Given this list of marker genes MRPL9, B3GNT2, TMEM165, BBS12, AIMP2, CDK5RAP1, PWWP2B, BAIAP2-DT, RBM41, RELL1 (RELT like 1), RRP1B, TERF2, RNF44, EXOSC2, C16orf54, PSTK, PROSER1, ABCD3, PUS1, PSIP1, DDX51, OCEL1, MRPS27, GXYLT1, USP31 (NCBI Gene Id 57478), FAM118B, NAA40, MCAM, RBM4B, ANKMY2 (ankyrin repeat and MYND domain containing 2), ZFP82, CALM2, ZSCAN18, CMAS, LTV1, CAPRIN2, MAP3K5, JMY, RAP1A, TMCO3, ZNF500, ELP2, ZNF77, BTD, TGFBR2, ATOSA (NCBI Gene Id 56204), MTREX, TAF1, ZNF112, TRERF1, LONP2, IER5L, ZBTB44, COMMD8, AGO4, WDSUB1, DOK3, ELP1, HECTD1, MRPL34, RRS1, NDUFA5, MYCL, LRIG2, GSKIP, AGL, MOAP1, DGCR2, ZNF623, IL1R1, FBXW2, SET, UTP11 (UTP11 small subunit processome component), BRD3, PRDM2, RACGAP1, MDM1, MAP3K2, COMMD2, ZNF573, NUP42, AGTPBP1, TDRKH, DUT, INPP4A, NUDT6, FBXO21, TSPYL5, MRFAP1L2 (NCBI Gene Id 93623), VPS33B, TMX3, UBR5, GPATCH11 (G-patch domain containing 11), SLC25A38, SPICE1, WDR54, OXA1L, YWHAG, RNF2, DUSP7, HEATR5B (NCBI Gene Id 54497), DDX55, SLC25A48, TSN, SAP30, MIDEAS, TMEM230 (NCBI Gene Id 29058), NADK2, TRAPPC11, MTMR12, LRRC47, WDR12, SHB, ABHD15, SHPK, KBTBD6, LRRC8A, KDM4B, HNRNPA0, EIF2B1, C9orf40, TSC22D3, CEP76, MCEE, SOCS6, MRPL10, AIP, YPEL2, AFG3L2, GBA2, COPS6, DCAF13, CAMK2G, ZFP90, PRIMPOL, SHQ1, MRPS18B, PFDN4, MRTFB, TSC1, MIEF1, REXO4, MKRN2, TFB2M, MSH2, RAB32, SPOUT1, ZNF263, MSTO1, RFC5, MBLAC2, AP4B1, LDAH, UBE4B, COX15, CSTF1, PPAT, NOP2, MCAT, HLTF, BCLAF1, ORC5, ETFB, RAD50, GAB3, FAM234B, ALG6, APEX1, NTHL1, ARMCX5, PAQR4, ZNF318, PRPSAP2, BIVM, PGAP3, ARB2A, NSMAF, MRPS11, LAT2, NOSIP, FRAT2, PEX5, THYN1, MYG1, CEP68, MSH6, LRR1, LZTFL1, ZNF57 (zinc finger protein 57), CFAP20, SLC35F6, FOXRED1, FEN1, ACTL6A, FRY, TMEM209, HNRNPAB, HAUS1 (HAUS augmin like complex subunit 1), PALB2, here is a description of the gene set: Genes up-regulated in comparison of polysome bound (translated) mRNA before and 4 h after LPS (TLR4 agonist) stimulation. Human Gene Set: GSE14000_UNSTIM_VS_4H_LPS_DC_TRANSLATED_RNA_UP from publication Ceppi M, Clavarino G, Gatti E, Schmidt EK, de Gassart A, Blankenship D, Ogola G, Banchereau J, Chaussabel D, Pierre P (PMID 19943945) Dendritic cells (DCs) are the sentinels of the mammalian immune system and they undergo a complex maturation process mediated by activation upon pathogen detection. Recent studies described the analysis of activated DCs by transcriptional profiling, but translation regulation was never taken in account. Therefore, the nature of the mRNAs being translated at various stages of DC activation was determined with the help of translational profiling, which is the sucrose gradient fractionation of polysomal-bound mRNAs combined to microarrays analysis. Total and polysomal-bound mRNA populations were compared in immature (0h) and LPS-stimulated (4h and 16h) human monocyte-derived DCs with the help of Affymetrix microarrays. Biostatistical analysis indicated that 296 mRNA molecules are translationally regulated during DC-activation. The most abundant biological process among the regulated mRNAs was protein biosynthesis, indicating the existence of a negative feedback loop regulating translation. Interestingly, a cluster of 17 ribosomal proteins were part of the regulated mRNAs, indicating that translation may be fine-tuned by particular components of the translational machinery. Our observations highlight the importance of translation regulation during the immune response, and may favour the identification of novel gene clusters or protein networks relevant for immunity. Our study also provides information on the possible absence of correlation between gene expression and real protein production in DCs. species: Homo sapiens